Given this list of marker genes SRC, CSNK2B, CSNK2A1, MAP1LC3A, CSNK2A2, PGAM5, ATG5, ATG12, ULK1, MAP1LC3B, FUNDC1, here is a description of the gene set: Human Gene Set: REACTOME_RECEPTOR_MEDIATED_MITOPHAGY studied in species Homo sapiens Receptor Mediated Mitophagy